Given this list of marker genes Sox9, Il1a, Spry1, Foxj2, Foxp4, Dsg2, Spred2, Fgf10, Zeb1, Fgfr3, S1pr3, Reg3g, Kras, Hes1, Ezh2 (NCBI Gene Id 14056), Msx2, Frzb, Cited1, Notch1, Fst, Nkx6-3, Foxe3, Ctnnb1, Mir7-1, Id1, Vhl, Hes5, Smo, Spred3, Ccnd1, Ovol2, Stat1, Six2, Xdh, Hoxa7, Foxp1, Notch4, Pinc, Dll1, Extl3, Nodal, Trp63, Gdf3, Yap1, Vegfa, Osr1, Cav1, Sall1, Jag1, Srsf6, Tbx3, Ifng, Acvrl1, Csf1r, Tgfb2, Tgfbr1, Spred1, Msx1, Spry2, Mmp9, Reg3a, here is a description of the gene set: Mouse Gene Set: GOBP_NEGATIVE_REGULATION_OF_EPITHELIAL_CELL_DIFFERENTIATION studied in species Mus musculus Any process that stops, prevents, or reduces the frequency, rate or extent of epithelial cell differentiation.